The following is a description of a gene set: Cell-cell signaling between presynapse and postsynapse, across the synaptic cleft, that modulates the synaptic transmission properties of the synapse. studied in species Homo sapiens Human Gene Set: GOBP_TRANS_SYNAPTIC_SIGNALING_MODULATING_SYNAPTIC_TRANSMISSION, and this is the list of marker genes: SLITRK5 (SLIT and NTRK like family member 5), PLG, CBLN2, EFNB3, PLAT, F2R (coagulation factor II thrombin receptor), CBLN4, GUCY1A1, CBLN1, CNRIP1, NTRK2, NEO1, IGSF21, SYT4, CNR2, FAAH